Given this list of marker genes DDB1, PML, BAHD1, KDM3B, DGCR11, CDC25C, MYL2, PAX8, PSD4, PIGB, HNRNPL, GFUS, SETD1B, WDR62, TMEM94 (transmembrane protein 94), AP3B1, SIK3, KHNYN (NCBI Gene Id 23351), DDX11, SLC12A4, TPMT, HMG20B, NDST1, GTF2F1, ENTREP3, RASSF7, SLC6A9, USP11, ADAM15, DHRS1, TUB, PFDN1, PTPN9, RABAC1, MR1, CRHR2, SCAMP5 (secretory carrier membrane protein 5), POLR2A, HMGXB3, ENTREP1, DYRK2 (dual specificity tyrosine phosphorylation regulated kinase 2), ADAMTSL2, TCOF1, MGAT1, MC2R, KMT2D, PRPH, RBM8A, LINC00928, COPS6, PVT1, PRKCSH, CRYBA4, ZFPL1, ARPC4, CNOT4, CRCP, IFT140, B4GALT3, LDB1, EML3, PKMYT1, IGHMBP2, MOK, NELFB, MMP25, VAMP3, RXRB, TUBGCP2, PMF1, GRB2, ARAF, SLC5A2, TSPO2, PPP1R10, USP19, PMS2P3, CASP2, DCAF7, FDXR, ILVBL, FKBP15, ALDH4A1, PCGF1, GSK3A, GRK6, PAIP2B, MTX1 (NCBI Gene Id 4580), CNP, SH2B1, ST14, ARHGEF1, WWOX, MVK, PITPNM1, CSNK1D, ZKSCAN3, FANCG, M6PR, MPP2, DIP2C, IKBKG, CNPPD1, ANKRD12, NUDT3, PLIN3, AP2A2, ORC1, SLC22A24 (solute carrier family 22 member 24), GHITM, SLC9A1, MCM3AP, PARN, NFRKB, IGSF9B, CNTN1, RPRD2, CAMK2B, ZBED1, ARSL, PHB1, GPR35, PCBP3, TRA2A, OTUB1 (OTU deubiquitinase, ubiquitin aldehyde binding 1), DRG2, RPS6KB2, HSF4 (NCBI Gene Id 3299), SFSWAP, LSM12, CSNK2A1, MCRS1, ZNF592, RABGGTA, CAMSAP1, RPA2, CIB1, here is a description of the gene set: species: Homo sapiens Neighborhood of IKBKG Human Gene Set: MORF_IKBKG Neighborhood of IKBKG inhibitor of kappa light polypeptide gene enhancer in B-cells, kinase gamma in the MORF expression compendium